The following is a description of a gene set: Reactome Pathway: Adenylate cyclase inhibitory pathway studied in species Homo sapiens Guanine nucleotide-binding protein G(i) alpha (Gi-alpha) inhibits adenylate cyclase, thus inhibiting the production of cAMP from ATP and ultimately decreasing the activity of cAMP-dependent protein kinase. part of: Activation of GABAB receptors; G-protein mediated events, and this is the list of marker genes: ADCY2, ADCY3, ADCY6, ADCY1, GNAI2, ADCY8, ADCY4, ADCY5, GNAI3, GNAL, GNAI1, ADCY9, GNAT3, ADCY7